Given this list of marker genes P3h2, Adamts3, Col5a1, Pxdn, Col9a3, Col28a1, Plod1, Col15a1, Col13a1, Pcolce, Col3a1, Col4a2, P4ha2, Col6a2, Lox, Tll2, Col25a1, Pcolce2, Col4a5, Col11a2, Col16a1, Col6a5, Col9a1, Col5a3, Col10a1, P4ha1, Mmp20, Col18a1, Col6a3, Mmp3, Col4a3, Col17a1, Col9a2, Mmp13, Bmp1, Col4a4, Plod2, Col19a1, Adamts2, Loxl2, Colgalt2, Tll1, Ctss, Loxl3, Colgalt1, Col8a1, Serpinh1, Col6a1, Col7a1, Col14a1, Col8a2, Col22a1, Col4a1, Col2a1, P4hb, Adamts14, Mmp9, BC051665, Ctsb, Col6a6, Col12a1, Col5a2, Col11a1, Col4a6, Mmp7, Col1a1 (collagen, type I, alpha 1), P4ha3 (procollagen-proline, 2-oxoglutarate 4-dioxygenase (proline 4-hydroxylase), alpha polypeptide III), Col26a1 (collagen, type XXVI, alpha 1), Plod3, Loxl4, Col23a1, P3h3, Ctsl, Loxl1, Col1a2, Col20a1, here is a description of the gene set: Collagen formation Mouse Gene Set: REACTOME_COLLAGEN_FORMATION studied in species Mus musculus